The following is a description of a gene set: studied in species Mus musculus Any process that modulates the frequency, rate or extent of the cascade of processes induced by the cell cycle regulator phosphoprotein p53, or an equivalent protein, in response to the detection of DNA damage. Mouse Gene Set: GOBP_REGULATION_OF_DNA_DAMAGE_RESPONSE_SIGNAL_TRANSDUCTION_BY_P53_CLASS_MEDIATOR, and this is the list of marker genes: Ankrd1, Npm1, Pttg1ip, Zfp385a, Eef1e1, Hic1, Kdm1a, Smyd2, Yju2, Sox4, Dyrk1a, Ifi211, Psmd10, Mdm2, Sirt1, Ddx5, Mif, Marchf7, Cd74, Atr, Snai2, Pla2r1, Snai1, Trp53, Ifi205, Atm, Ing4, Znhit1, Cd44, Pmaip1, Cdkn2a, Spred1, Ifi204, Rpl26, Cops3, Pcbp4, Twist1 (twist basic helix-loop-helix transcription factor 1), Kmt5a, Zmpste24, Dyrk3, Spred2